Given this list of marker genes PAX4, KLF11, BLK, APPL1, PHKG2, ZFX, HNF1A, INS, NEUROD1 (NCBI Gene Id 7853), PDX1, HNF4A, GNAS, PHKB, KCNJ11, GCK, PHKA2, CEL, SLC37A4, ABCC8, here is a description of the gene set: A benign tumor of the liver of presumably epithelial origin. Human Gene Set: HP_HEPATOCELLULAR_ADENOMA Hepatocellular adenoma species: Homo sapiens